Given this list of marker genes CCL7, CXCL11, IFNA4, ENPP2, IFNE, IFNG, SAMD9L, LAMP3, NEXN, IFNA21, IFNA17, IFNA1, CCL3, OAS2, IFNA16, OAS3, IFIT2 (NCBI Gene Id 8375), IRF7, IFNA14, IFNA2, IFNB1, IFNA8, IFNA10 (interferon alpha 10), HSH2D, IFNA7, IL6, TNF, CD38, RIGI, TNFSF10, STAT1, IFNA5, XAF1, EIF2AK2 (eukaryotic translation initiation factor 2 alpha kinase 2), TLR3, IFIH1, IL15, SLAMF7, OAS1, here is a description of the gene set: from publication Erwin-Cohen R, Porter A, Pittman P, Rossi C, Dasilva L (PMID 22617845) Human Gene Set: ERWIN_COHEN_PBMC_TC_83_AGE_18_45YO_NAIVE_NOT_PREVIOUSLY_IMMUNIZED_24HR_DEG_CANONICAL_PATHWAY_MEMBERS_UP Venezuelan equine encephalitis virus (VEEV) is a positive-strand RNA Alphavirus endemic in Central and South America, and the causative agent of fatal encephalitis in humans. In an effort to better understand the mechanisms of infection, including differences between people who produce a neutralizing antibody response to the vaccine and those who do not, we performed whole genome transcriptional analysis in human PBMCs exposed in vitro to the live-attenuated vaccine strain of VEEV, TC-83. We compared the molecular responses in cells from three groups of individuals: naive; previously vaccinated individuals who developed a neutralizing antibody response to the vaccine (responders); and those who did not develop a neutralizing antibody response to the vaccine (nonresponders). Overall, the changes in gene expression were more intense for the naive group after TC-83 challenge and least potent in the nonresponder group. The main canonical pathways revealed the involvement of interferon and interferon-induced pathways, as well as toll-like receptors TLR- and interleukin (IL)-12-related pathways. HLA class II genotype and suppression of transcript expression for TLR2, TLR4 and TLR8 in the nonresponder group may help explain the lack of vaccine response in this study group. Because TL3 and TLR7 transcripts were elevated in all study groups, these factors may be indicators of the infection and not the immunological state of the individuals. Biomarkers were identified that differentiate between the vaccine responder and the vaccine nonresponder groups. The identified biomarkers were contrasted against transcripts that were unique to the naive population alone upon induction with TC-83. Biomarker analysis allowed for the discernment between the naive (innate) responses; the responder (recall) responses; and the nonresponder (alternative) changes to gene transcription that were caused by infection with TC-83. The study also points to the existence of HLA haplotypes that may discriminate between vaccine low- and high-responder phenotypes. studied in species Homo sapiens Genes up-regulated in peripheral blood mononuclear cell 24h vs 0h in adults (18-45) (naive (not previously immunized)) after exposure to Live attenuated vaccine TC-83, time point 24H. Comment: significant genes chosen for membership in canonical pathways